Given this list of marker genes GIMAP1, DEF6, CMKLR1 (chemerin chemokine-like receptor 1), GCLC, ADAMTS10 (ADAM metallopeptidase with thrombospondin type 1 motif 10), SMAP2, CLSPN, FPR2, CDCA8, CCL24, APOBEC3B, H1-5, PID1, ALDH1B1, SESN1, CRACR2A, H2AZ2, ELP6, PLK1, COLEC12, MCM4, ALOX5, PRC1, RGS18, PRMT7, MILR1, SFXN2, SERPINB1, MEF2C, TRIM5, DTL, GIMAP6, EMP2, CD93, ARHGEF6, DSN1, MCM3, CDC6, TLN2, NUDT3, ST8SIA4 (NCBI Gene Id 7903), CPED1, SRSF2, MIS18A, SORL1, NLRP3 (NCBI Gene Id 9558), METTL17, BIRC5, RASSF2, DEPTOR, ITM2B, ARHGAP35, MLLT3, HGSNAT, CENPI, NIPSNAP3B, L3MBTL2 (L3MBTL histone methyl-lysine binding protein 2), ANXA2R-OT1, NAIP, ATP8B4, ANTXR1, SERPINB8, VSIG4, ZNF367, LCLAT1, PARL, LAT2, RNASE6, CCNA2, MCM10, GSTCD, IFIT1, SNRPF (small nuclear ribonucleoprotein polypeptide F), CYREN, TACC3, BCL11A, H3C2, LILRB2, PRPF4, PAK1, GINS2 (NCBI Gene Id 51659), TPX2, GARNL3, PPIL1, GRK2, CIP2A, CDC25A (NCBI Gene Id 993), CEP55, POLE, SELL (NCBI Gene Id 6402), CTPS1, NCOA4, HJURP, TRAF3IP3, FAM168A, MKI67 (NCBI Gene Id 4288), CDK1, GIMAP8, C3AR1, CDC45, LXN, TBC1D14, ELP3, CALM1, CARD6, CD101, INPP4A, KIF23, PIK3R3, MAGOHB, GANAB, TMEM87B, TMEM119, CCNB2, TYMS (thymidylate synthetase), TNFSF8, HELLS, RAPH1, ZFHX3, RNASE2CP, NCAPG2 (NCBI Gene Id 54892), C5AR2, PARP1, IL13RA1, ZNF502, ANTXR2, LTA4H, BLNK, CD163, RFC3, HFE, TNRC18, SHQ1, POC1A, GIMAP5, STS, ASF1B, RHOA, PTGER4, TNFSF10, VDAC3, MXD4, ATF7, FPR1, GPR82, SLC9A9, PMFBP1, ATG7, LSM5, SELPLG, LMNB1 (NCBI Gene Id 445266), CRYBB1, JAML, MELK, SORD, PRIM2 (DNA primase subunit 2), GAPT, KPNA2, BST1, UBE2T, COQ2, FBN2, SIRPB2, SHCBP1, LANCL2, AIF1, GPR34, IDH2, SNRPD1, GPR65, GIMAP7, STING1, SESN3, HSPA5, FRMD4B, RCSD1, RRM1, CLECL1P, TCF19, STAB1, GPR132, LTBP2, AOAH, YY2, ELK3, BCS1L, RRM2, EAF2, C4orf46, UHRF1, CENPW, RHOBTB1, MAML3, GCNT1, ABI3, CCNE2, ADAM28, STEAP3, PRIM1, FUT8, here is a description of the gene set: species: Homo sapiens Human Gene Set: GSE22313_HEALTHY_VS_SLE_MOUSE_CD4_TCELL_DN from publication Cuda CM, Li S, Liang S, Yin Y, Potula HH, Xu Z, Sengupta M, Chen Y, Butfiloski E, Baker H, Chang LJ, Dozmorov I, Sobel ES, Morel L (PMID 22180614) Genes down-regulated in CD4 T cells: healthy versus systemic lupus erythematosus (SLE). Sle1a.1 is part of the Sle1a lupus susceptibility locus which results in the production of activated and autoreactive CD4+ T cells as well as a reduction in the peripheral regulatory T cell (Treg) pool. Sle1a.1 CD4+ T cells showed a defective response to retinoic acid (RA) expansion of TGFβ-induced Tregs. At the molecular level, Sle1a.1 corresponds to an increased expression of a novel splice isoform of Pbx1, Pbx1-d. Pbx1-d over-expression is sufficient to induce an activated/inflammatory phenotype in Jurkat T cells, and to decrease their apoptotic response to RA. PBX1-d is expressed more frequently in lupus patients than in healthy controls, and its presence correlates with an increased memory T cell population. These findings indicate that Pbx1 is a novel lupus susceptibility gene that regulates T cell activation and tolerance.